The following is a description of a gene set: from publication Hale JS, Youngblood B, Latner DR, Mohammed AU, Ye L, Akondy RS, Wu T, Iyer SS, Ahmed R (PMID 23583644) species: Homo sapiens Genes up-regulated in CD4 SMARTA T cells: naïve versus Th1 memory. CD4 T follicular helper (Tfh) cells provide the required signals to B cells for germinal center reactions that are necessary for longlived antibody responses. However, it remains unclear whether there are CD4+ memory T cells committed to the Tfh lineage after antigen clearance. Using adoptive transfer of antigen-specific memory CD4+ subpopulations (based on CXCR5 and Ly6c expression)in the LCMV infection model, we found that there are distinct memory CD4+ T cell populations with commitment to the Tfh and Th1 lineages. Our conclusions are based on gene expression profiles, epigenetic studies and phenotypic and functional analysis. The gene expression profiles of virus-specific CD4 T cell subets at effector and memory stages is presented here. Human Gene Set: GSE43863_NAIVE_VS_MEMORY_TH1_CD4_TCELL_D150_LCMV_UP, and this is the list of marker genes: PSORS1C2, ARL9, CFAP157, NOMO3, GVINP1, KAT6B, ATF3, BEX1, TAS2R40, SIM1, CARINH, PARP14, MYLK4, OR5J2, ZNF619, PCDH18, PSME2, CIITA, PPP1R14D, LINC00612, RIPK2, LRRTM2, CCNP, APOL6, THEMIS2, RPS10P7, SRCIN1, CGAS, CCL8, ENPP3, LOXL4, PSMB9, GCH1, LPIN2, MAF, DEFB4A, ZNF341, POLR2H, UPK1B, DDX60L, HLA-DMB, SCRN1, HPYR1, SAMD9L, IL15RA, ZNF204P, CASP10, DNAJC1, KRT86, LCP2, PCDH17, KLF2, FIRRE, TAP1, WARS1, IRF1, AIM2, HMGA2, VCAN, TNFSF13B (TNF superfamily member 13b), ISG15, TLCD2, GBP5, REG4, CD207, ATXN7, ENSG00000291149, IFIT3, MAS1, SLCO2B1, H2BC7, MCL1, FOXP1-IT1, C4orf19, DHX9-AS1, ADAM18, RNPC3, RNF213, OR1J2, TREML5P, UNC13C, TTC21B, STK40, LINC00870, TRAFD1, LONRF1 (NCBI Gene Id 91694), FKBP6P2, RASAL2 (NCBI Gene Id 9462), EPSTI1, NXNL1, LINC01270, ABHD11, C5, MAP2, PIEZO2, DGKG, ENSG00000176984, MYO1H, SLC17A4, RHPN2, LMO7 (LIM domain 7), PRR34, TNC, NLRC5, TAS2R13, HTR1B, TRIM21, PUS7L, CMPK2 (NCBI Gene Id 129607), CD274, CD244, LMX1A, BACH1, KRBA2, GIMAP5, WDFY4, RHOXF1, IDO1, OFCC1, TMEM196, C21orf91, PRKCQ, LHX2, CCL2 (C-C motif chemokine ligand 2), LINC02603, FGD2 (NCBI Gene Id 221472), CLEC3A, NCALD, RTP4 (receptor transporter protein 4), CD74, ISG20 (interferon stimulated exonuclease gene 20), HAPLN1, SPARCL1, CXCL11, C8orf17, CAMK2A, GBP1, TAF5LP1, SP100, RNASE7, CDK15, DRC1, ENSG00000253557, SOX6, ZNF554, DDN, PLAAT4, FHIP1A, ZNF785, CEBPD, CXCL10, TSSK3, RGCC, HLA-DRB6 (NCBI Gene Id 3128), VEGFC, CD209, ODF4, ENC1, ELOVL3, LINC00305, HOXD4, DNAAF1, HK1, CILP, LINC00307 (long intergenic non-protein coding RNA 307), KLHL29, RIGI, KIF28P, ZBTB11-AS1, ZNF10, GBP2, TMEM72-AS1, APOL1, DNAH10, UBE2L6, SYT2, POPDC3, KALRN, ELF5, PDE10A, PLA1A, STAT2, IFI30, FMO3, GSTK1, MACROD2, RNF183, BMP5, SP110, SERPINA9